Given this list of marker genes BCS1L, POLR3A, ALDOB, FOCAD, RMND1, RRM2B, VPS4A, HADH, EARS2, GLRX5, ACSL5, FBP1, NAA10, CASZ1, WDPCP (NCBI Gene Id 51057), HADHB, ACADS, SLC11A2, GNAS, BBS4, ATP6AP1, CEP290, PRDM16, HNRNPA1, ETFA, PLAAT3, TOMM7, SAR1B, ADK, VPS33A, POLG2, NFS1, UNC45A, HSPG2, SLC25A13, SPEN, SCLT1, APOB, ALMS1, AGPAT2, AKR1D1, BBS1, ZPR1, SLC40A1, ETFB, PNPLA2, DOCK2, LIG3, CIDEC, MTTP, SDHA, HMGCS2, ACADM, ATP6AP2, PTRH2, CARS2, HNF4A, FARS2, TTC8, NDUFAF1, TRAPPC11, HMGCL, PHKB, LMNB2, LARS1, UBE4B, IFT74, TBX1, SDCCAG8 (SHH signaling and ciliogenesis regulator SDCCAG8), SLC25A20, PYGL, ABCG5, SURF1, COX15, GPD1, DEF6, PIGA, MRPS7, SPTBN1, CPT2, BBS5, LDLRAP1, FARSB, ABCG8, BBS10, PLIN1, TRIM32, TFAM, MMP23B, TKFC (triokinase and FMN cyclase), RERE, IARS1, ACAD9, FTH1, CAV1, BSCL2, CAVIN1, PGM1 (phosphoglucomutase 1), MRPL44, ARMC5, CCDC115, CBS, PCSK9, LIPA, BLM, HNF1B, PDPN (NCBI Gene Id 29912), CLPB, HEPACAM, TYMP, IFT27, ARL6, DNAJC19, BBIP1, CYP19A1, GNB2, CEP19, NGLY1, LYRM4, BBS2, TRMU, NHLRC2, SCAPER, ACADVL, HADHA, HBB (hemoglobin subunit beta), PCK2, PPARG, RNU7-1, IFIH1, MTX2, ETFDH, DPM1, PHKA2, SLC37A4, POLG, FARSA, KDM1A (NCBI Gene Id 23028), FOS, YARS1, COA8, XRCC4, SLC30A10, HNRNPA2B1, SLC51B, SLCO1B3, ABHD5, MPV17, DHCR7, MKS1 (NCBI Gene Id 54903), DGUOK, CPT1A, STEAP3, SLCO1B1, KMT2B, AKT2, RINT1, HSD17B4, BBS12, MT-TN, TMEM199, ATP7B, BBS9, MARS1, APOE, BMP6, LDLR, MKKS, PCK1, SKI, KCNAB2, BBS7, SCO1, PMM2, POLD1, PCYT1A, LRPPRC, SLC22A5, LUZP1, ACOX1, CP, SHARPIN, DDOST, NPHP1, MCCC1, FTL, CFAP418, LMNA, TARS2, VCP, MICOS13, NSMCE2, LIPE, IFT172, MRPL3, SUCLG1, CYP7A1, PTEN, PRKCZ, SLC2A2, GABRD, LZTFL1, PHKG2, here is a description of the gene set: Human Gene Set: HP_ABNORMAL_LIVER_METABOLITE_CONCENTRATION species: Homo sapiens The concentration of a metabolite in the liver is above or below the limits of normal. Abnormal liver metabolite concentration